Given this list of marker genes QDPR, ADI1, RUNDC3B, TSKU, GSTA3, FAH, PIK3C2G, ACSL5, HGD, GCKR, FAM13A, HLF, ANKRD13C-DT, ABCG2, ALDH1L1, here is a description of the gene set: species: Homo sapiens Hepatocellular carcinomas (HCCs) are a heterogeneous group of tumors that differ in risk factors and genetic alterations. We further investigated transcriptome-genotype-phenotype correlations in HCC. Global transcriptome analyses were performed on 57 HCCs and 3 hepatocellular adenomas and validated by quantitative RT-PCR using 63 additional HCCs. We determined loss of heterozygosity, gene mutations, promoter methylation of CDH1 and CDKN2A, and HBV DNA copy number for each tumor. Unsupervised transcriptome analysis identified 6 robust subgroups of HCC (G1-G6) associated with clinical and genetic characteristics. G1 tumors were associated with low copy number of HBV and overexpression of genes expressed in fetal liver and controlled by parental imprinting. G2 included HCCs infected with a high copy number of HBV and mutations in PIK3CA and TP53. In these first groups, we detected specific activation of the AKT pathway. G3 tumors were typified by mutation of TP53 and overexpression of genes controlling the cell cycle. G4 was a heterogeneous subgroup of tumors including TCF1-mutated hepatocellular adenomas and carcinomas. G5 and G6 were strongly related to beta-catenin mutations that lead to Wnt pathway activation; in particular, G6 tumors were characterized by satellite nodules, higher activation of the Wnt pathway, and E-cadherin underexpression. CONCLUSION: These results have furthered our understanding of the genetic diversity of human HCC and have provided specific identifiers for classifying tumors. In addition, our classification has potential therapeutic implications because 50% of the tumors were related to WNT or AKT pathway activation, which potentially could be targeted by specific inhibiting therapies. Down-regulated genes in hepatocellular carcinoma (HCC) subclass G12, defined by unsupervised clustering from publication Boyault S, Rickman DS, de Reyniès A, Balabaud C, Rebouissou S, Jeannot E, Hérault A, Saric J, Belghiti J, Franco D, Bioulac-Sage P, Laurent-Puig P, Zucman-Rossi J (PMID 17187432) Human Gene Set: BOYAULT_LIVER_CANCER_SUBCLASS_G12_DN